Given this list of marker genes NDRG1, CHM, TP73, BCL2L14, BIRC5, TP53I3, BCL6, PPP1R13B, TP53BP2, RABGGTA, TP63, PERP, RABGGTB, TP53, here is a description of the gene set: The exact mechanisms of action of several other pro-apoptotic TP53 (p53) targets, such as TP53I3 (PIG3), RABGGTA, BCL2L14, BCL6, NDRG1 and PERP, remain uncertain. Reactome Pathway: TP53 regulates transcription of several additional cell death genes whose specific roles in p53-dependent apoptosis remain uncertain part of: TP53 Regulates Transcription of Cell Death Genes studied in species Homo sapiens